The following is a description of a gene set: Human Gene Set: PURBEY_TARGETS_OF_CTBP1_AND_SATB1_DN from publication Purbey PK, Singh S, Notani D, Kumar PP, Limaye AS, Galande S (PMID 19103759) Special AT-rich binding protein 1 (SATB1) acts as a global regulator of gene expression by recruiting various corepressor or coactivator complexes, thereby establishing a unique chromatin structure at its genomic targets in a context-dependent manner. Although SATB1 acts predominantly as a repressor via recruitment of histone deacetylase 1 (HDAC1) complexes, the precise mechanism of global repression is not clear. Here we report that SATB1 and C-terminal binding protein 1 (CtBP1) form a repressor complex in vivo. The interaction occurs via the CtBP1 interaction consensus motif PVPLS within the PDZ-like domain of SATB1. The acetylation of SATB1 upon LiCl and ionomycin treatments disrupts its association with CtBP1, resulting in enhanced target gene expression. Chromatin immunoprecipitation analysis indicated that the occupancy of CtBP1 and HDAC1 is gradually decreased and the occupancy of PCAF is elevated at the SATB1 binding sites within the human interleukin-2 and mouse c-Myc promoters. Moreover, gene expression profiling studies using cells in which expression of SATB1 and CtBP1 was silenced indicated commonly targeted genes that may be coordinately repressed by the SATB1-CtBP1 complex. Collectively, these results provide a mechanistic insight into the role of SATB1-CtBP1 interaction in the repression and derepression of SATB1 target genes during Wnt signaling in T cells. Genes down-regulated in HEK-293 cells (fibroblast) upon knockdown of both CTBP1 and SATB1 by RNAi. studied in species Homo sapiens, and this is the list of marker genes: HAX1, COPS2, C5orf22 (chromosome 5 open reading frame 22), VWA1, CCDC88A (coiled-coil domain containing 88A), MED16, RELA, PANX3, FN3KRP (fructosamine 3 kinase related protein), SLC30A6, PNPO, SMAD7, AIMP2, CNTN4, ITLN1, PILRB, GPR4, POLH, PDCD2, SCAMP1, SCAMP4 (secretory carrier membrane protein 4), TREH, ACOXL, ARHGAP1, SCNN1B, KHSRP, NUPR1, LRCH3, P3H2, ENSG00000261697, HACD1, ZNF282, GLS, CPNE1, CA10, SNRNP40 (NCBI Gene Id 9410), MDM2, HOXA1 (NCBI Gene Id 3198), RAVER1, HYAL3, CNTNAP3B, PRCC, MPO, TOB2, PHF5A, SIX5, TRIM14, HSPB1, B3GNT3, GLI4 (NCBI Gene Id 2738), PPY, GCSAM (germinal center associated signaling and motility), ATP6V0A1, EXOC7, CDK2AP2, ATP6V1B2, MYO5A, RSU1, AKAP11 (NCBI Gene Id 79988), GRM7, HIF3A, HNRNPL, ENSA, CLEC1B, GBA1LP, DDX28, ICOSLG, TIMM23, KLRC1, CMPK2 (NCBI Gene Id 129607), TNFSF11, GCDH, SWT1, ALX1, ROBO1, WAC, AIFM2, POMGNT1, PDZD11, FGF12, MLLT10, PMVK, EIF3J, MRPL1, UHRF1, MSTO1, SEC24D, CCDC22, BRF1, GUCY1B2, CDKN2A, RHOJ, RTKN, SPNS1 (SPNS lysolipid transporter 1, lysophospholipid), FAM120AOS, SF3A1, GATC, GET3, NTSR2, UBXN8, CCNF, SORD, PLCG1, ATCAY (NCBI Gene Id 85300), ATXN7L1, LSM3, CDC42EP4 (CDC42 effector protein 4), SUPT4H1, TMEM38B, GP9, SPINK1, GABRB3, CDC42EP3, PTGIS, TSPAN8, MPZL1, TIAL1, NDUFC1, MGLL, CACNA1C, CCNT1, ALDH18A1, HYAL2, SRPRB, CNKSR2, RAP1A, PAF1, PDXK, ALDH1B1, MAP2K2, ZSWIM3, DIO2, SLC4A7, PDCD6, WDR46 (NCBI Gene Id 9277), TMPRSS4, PRAMEF1, EDC3, JUND, TMEM222, MAPK7, CENPN, RECQL5, PWWP2B, ZMPSTE24, PPIF, CBX6, HPN, ARID3A, CCDC62, UBASH3A, IL2RG, PLCL1 (NCBI Gene Id 5334), PARD6A, PON3, SERINC3, SERAC1, AMZ2 (NCBI Gene Id 51321), FARSA, ACOT8, NOL8